Given this list of marker genes TNKS, RTEL1, RAD50, HNRNPD, ERCC1, XRCC1, ERCC4, TERF2, NABP2, TNKS2, USP7, ATM, NBN, SMG6, here is a description of the gene set: Human Gene Set: GOBP_REGULATION_OF_TELOMERE_CAPPING Any process that modulates the frequency, rate or extent of telomere capping. studied in species Homo sapiens